The following is a description of a gene set: Any process that activates or increases the frequency, rate or extent of type I hypersensitivity, a type of inflammatory response. studied in species Mus musculus Mouse Gene Set: GOBP_POSITIVE_REGULATION_OF_TYPE_I_HYPERSENSITIVITY, and this is the list of marker genes: Fcgr3, Ighg1, Btk, Fcer1g, Ighg2b, Fcer1a